The following is a description of a gene set: Increased urinary potassium species: Homo sapiens Human Gene Set: HP_INCREASED_URINARY_POTASSIUM An increased concentration of potassium(1+) in the urine., and this is the list of marker genes: CLCNKA, GATM, KCNJ1, SLC12A1, SLC34A1, CLCNKB, BSND, EHHADH, NDUFAF6